Given this list of marker genes SOD1, ABCD1, PPP2R2B, PNPT1, LGI3, KCNQ2, PNKD, ATP13A2, PRKCG, CACNA1G, ITPR1, MORC2, SPTBN2, TBCK, GSN, ADCY5, UCHL1, HINT1, ATP2A1, KCNA1, here is a description of the gene set: Myokymia consists of involuntary, fine, continuous, undulating contractions that spread across the affected striated muscle. species: Homo sapiens Human Gene Set: HP_MYOKYMIA Myokymia